The following is a description of a gene set: from publication Chen Y, Wang X (PMID 31504780) Human Gene Set: MIR4795_5P Genes predicted to be targets of miRBase v22 microRNA hsa-miR-4795-5p in miRDB v6.0 with MirTarget v4 prediction scores > 80 (high confidence targets). species: Homo sapiens, and this is the list of marker genes: FSTL1, RBM5, PROX1, CAMSAP2, ERCC4, SLAMF6, ANGPT4, ATOSA, CFHR3, PRRG1, DNPEP, PLEKHA8, GRM5, DOK2, ADD3, GALNT16, CNIH3, EPB41L2, SLC14A1, SPARCL1, COBLL1, NFS1, MIER2, TERF2, TCF4, ZNF681, E2F3, DCBLD2, SPX, ZNF148, CAMK2D, UBE2H, CDH10, RIOX2, UNC5C, MARCHF2, ZNF124, KLHDC8A, EDAR, SHISA9, DYNAP (dynactin associated protein), PIP4P1, SATB2, GLB1, FNDC7, MAPK1, CACNA2D2, SSB, LUZP1, MOB1B, CEMIP, SHISA7, FMR1, NPAS3, SLC25A26, CBLIF, LYZL6, BLCAP, CELF3, STIM1, GYG1, ZNF316, ERMP1, UBASH3A, PKN2, AKAP10, CDH2, HDAC4, THTPA (NCBI Gene Id 79178), VCPKMT, PGK1, MTCL2